The following is a description of a gene set: studied in species Mus musculus The chemical reactions and pathways resulting in the breakdown of diacylglycerol, a glyceride in which any two of the R groups (positions not specified) are acyl groups while the remaining R group can be either H or an alkyl group. Mouse Gene Set: GOBP_DIACYLGLYCEROL_CATABOLIC_PROCESS, and this is the list of marker genes: Daglb, Dgkd, Apoa2, Plb1, Lipe, Dagla